Given this list of marker genes Rigi, Ubb, Irf3, Tnfaip3, Mavs, Rps27a, Cyld, Nlrx1, here is a description of the gene set: part of: DDX58/IFIH1-mediated induction of interferon-alpha/beta This event has been computationally inferred from an event that has been demonstrated in another species.<p>The inference is based on the homology mapping from PANTHER. Briefly, reactions for which all involved PhysicalEntities (in input, output and catalyst) have a mapped orthologue/paralogue (for complexes at least 75% of components must have a mapping) are inferred to the other species. electronically inferred by orthology from the curated human pathway species: Mus musculus Reactome Pathway: Negative regulators of DDX58/IFIH1 signaling